The following is a description of a gene set: species: Homo sapiens from publication Schaefer CF, Anthony K, Krupa S, Buchoff J, Day M, Hannay T, Buetow KH (PMID 18832364) Human Gene Set: PID_P53_DOWNSTREAM_PATHWAY Direct p53 effectors, and this is the list of marker genes: JMY, GADD45A, BAX, BCL2, TFDP1, CCNB1, APAF1, SMARCA4, ARID3A, RPS27L, COL18A1, POU4F1, SH2D1A, PLK3, BTG2, BCL2A1, CASP1, MSH2, TNFRSF10B, BCL2L14, SERPINE1, PMAIP1, DUSP5, TNFRSF10C, MMP2, PML (NCBI Gene Id 5371), BDKRB2, HIC1, NFYA, BCL6, PERP, PPP1R13B, AFP, APC, CTSD, TP63, HTT, RNF144B, IGFBP3, SCN3B, SP1, CSE1L, EP300 (NCBI Gene Id 2033), ATF3, CX3CL1, CARM1, TIGAR, MAP4K4, TP53INP1, PTEN, BBC3, TGFA, SNAI2, CDKN1A, TAP1, PRMT1, RCHY1, PPM1J, POU4F2, VDR, LIF, AIFM2, TP53I3, BCL2L2, SESN1, BID, SFN, STEAP3, FOXA1, GDF15, PYCARD, RRM2B, S100A2, CCNK, PCNA, E2F2, CASP10, EDN2, DROSHA, DKK1, FAS, SERPINB5, CAV1, RB1, PRDM1, TRRAP, E2F3, JUN, ZNF385A, TAF9, CREBBP, KAT2A, CCNG1, DUSP1, HGF, BNIP3L, FDXR, COP1, TYRP1, HDAC2, BCL2L1, TSC2, EPHA2, IRF5, TRIAP1, NLRC4, TP53BP2, NFYB, CASP6, PMS2, EGFR, TP53, DDB2, CD82, DDX5, TNFRSF10D, TADA2B, PRKAB1, CEBPZ, DDIT4, NFYC, GPX1, TP73, MDM2, MET, NDRG1, VCAN, PCBP4, MLH1 (mutL homolog 1), BAK1, E2F1, TNFRSF10A, PIDD1, SPP1, MCL1, RGCC, DGCR8